Given this list of marker genes Prkar2b, Prkcg, Camkk1, Prkar1b, Calm1, Pde1c, Adcy8, Adcy5, Camkk2, Prkca, Plcb3, Gnat3, Gnai1, Pde1b, Prkaca, Gna14 (NCBI Gene Id 14675), Adcy7, Prkacb, here is a description of the gene set: part of: Opioid Signalling This event has been computationally inferred from an event that has been demonstrated in another species.<p>The inference is based on the homology mapping from PANTHER. Briefly, reactions for which all involved PhysicalEntities (in input, output and catalyst) have a mapped orthologue/paralogue (for complexes at least 75% of components must have a mapping) are inferred to the other species. Reactome Pathway: G-protein mediated events electronically inferred by orthology from the curated human pathway studied in species Mus musculus